The following is a description of a gene set: Mouse Gene Set: GOBP_RESPONSE_TO_IRON_ION Any process that results in a change in state or activity of a cell or an organism (in terms of movement, secretion, enzyme production, gene expression, etc.) as a result of an iron ion stimulus. studied in species Mus musculus, and this is the list of marker genes: Cyp1a1, Ireb2, Bmp6, Hamp2, Lct, Hamp, Casp6 (caspase 6), Bcl2, Atg5, Drd2, Map1lc3a, Fxn, Mdm2, Aco1, Tfr2, Tfrc (NCBI Gene Id 76361), Slc25a39, Trf, Slc11a2, Snca, Becn1, Abat, Pdx1, Hfe, Gpld1, Alad, Tfap2a, B2m, Cybrd1, Slc6a3, Hif1a